The following is a description of a gene set: We have exploited a discrepancy in the oncogenic potential of autocrine and exogenous human growth hormone (hGH) in an attempt to identify molecules that could potentially be involved in oncogenic transformation of the human mammary epithelial cell. Microarray analysis of 19,000 human genes identified a subset of genes in a human mammary carcinoma cell line that were remarkably different in their response to autocrine and exogenous hGH. Autocrine and exogenous hGH also regulated 167 common genes. Semiquantitative reverse transcription-PCR confirmed differential regulation of genes by either autocrine or exogenous hGH. Functional analysis of one of the identified autocrine hGH-regulated genes, TFF3, determined that its expression is sufficient to support anchorage-independent growth of human mammary carcinoma cells. Small interfering RNA-mediated knockdown of TFF3 concordantly abrogated anchorage-independent growth of mammary carcinoma cells and abrogated the ability of autocrine hGH to stimulate oncogenic transformation of immortalized human mammary epithelial cells. Further functional characterization of the identified subset of specifically autocrine hGH regulated genes will delineate additional novel oncogenes for the human mammary epithelial cell. studied in species Homo sapiens Genes down-regulated in MFCF-7 cells (breast cancer) upon stable autocrine expression of HG1. Human Gene Set: XU_GH1_AUTOCRINE_TARGETS_DN from publication Xu XQ, Emerald BS, Goh EL, Kannan N, Miller LD, Gluckman PD, Liu ET, Lobie PE (PMID 15845533), and this is the list of marker genes: GP9, JAK1, ZNF217, TGIF2, MAGED2, SBK1, SULF1 (NCBI Gene Id 23213), NFYC, HPSE, MCF2L, RBPMS, MPRIP, ELOVL2, RSL1D1, TMEM164 (transmembrane protein 164), TMSB4X, RAB31, PCCB, MCPH1, GDF3, ST3GAL2, NBEA, ARMH3, SULF2, AGR2, PIK3CA, KRT80, IGFBP4, PPIP5K2, PREX1, CTNND2, PCLAF, PWAR1, SLC38A1, COL12A1, CDC42BPA, SLK, UBL3, DYRK1B, ADIPOR2, NUP50, SDHA, SLC39A10, CUX1, HSPA1B, SNORD62A, CMTR2 (NCBI Gene Id 55783), BAMBI, SLC22A23, DBN1, NR2F2, PTBP3, RPS6KB1, NAALADL2, DNAJC1, CACNG4, TIMP3, PODXL, ARMT1, RBFOX1, GSTM3, NUMA1, NRCAM, NPHS2, NDUFB8, PXDN, RAMP1, LXN, SERPINA5, MAP3K1, RBM7, ARID5B, ADCY1, CA2, IPO7, DDX39A (NCBI Gene Id 95781), TPM1, EFNB2, TJP1, PTPN3, GDAP1, EIF5, DSCAM, KDM5B, PUS7, CHD6, ISOC1, ESPN, ZNF138, NIBAN2, NAT1, SETD2, OLFM1, PMEPA1, XIST, UNC5C, PRLR, RETREG1, RHOQ, KCNK2, COQ4, LAMA5, EEIG1, TNNT3, CD44, THBS1, NETO2, RPL37, REL, HSPH1, MUC3A, TSPYL5, SEMA3C, IL36RN, POMT1, GPR180, B4GALT1, SCGB2A1, GPX4, UGDH (NCBI Gene Id 7358), PLK2, RELN, ULK1, EFNA5, HOOK1, PTPRK, CIT, NLN, TNFRSF4, EXOC3, PLAAT3